Given this list of marker genes Lpar3, Cga, C030013C21Rik, Clip3, 9930111H07Rik, Wnk4, Bnip2, Ryr1, Psors1c2, Nhsl2, Limk1, Fndc5, Mcf2l, Adam15, 4930573O16Rik, Nog, Speer3, Tmem88, Tnnt1, Tmem150a, Fgd4, Gm19265, Myo1h, Tox4, Tlr4, 5430427M07Rik (RIKEN cDNA 5430427M07 gene), 4930505O20Rik, 1700124L16Rik, Dhcr7, Akr1cl, Sult1e1, Gng10, Fn3k, Csrnp3, Snorc, Ckmt2, Spata24, Ccdc28b, Tmed7, Vsir, Syne2, Or13c7d (olfactory receptor family 13 subfamily C member 7D), Foxc1 (forkhead box C1), 1700025A08Rik, 1700026J14Rik, Lrrc58, Phykpl, Pygo2, Abtb3, Rassf8, Dmrtb1, Add2, Meg3, Nrgn (NCBI Gene Id 97578), Lrrc4, Armc2, Galntl6, Zcchc12, Fgf15, Ncln, Sez6, Tead1, 1700061E18Rik, Zfp358, Prelid2, Anks6, Sapcd1, Socs4, Gpatch2, Trappc3, Nfatc2ip, Acer2, Zfp560, Myo5c, Pdxdc1 (pyridoxal-dependent decarboxylase domain containing 1), Pax3, Kctd4, Mef2c, Fxyd1 (NCBI Gene Id 80524), Lonrf3, ENSMUSG00000135196, Gtf2f1, Cthrc1, 3110080O07Rik, Ripor1, Ppp2r2a, Xrn1 (5'-3' exoribonuclease 1), Scpep1, Lyzl4, Galnt4, Myo5b, Sigirr, Dph1, Epdr1, Ccdc88c, Taf1b, Sh2d4b, Ccdc125, Rasip1, Vmn1r239-ps, Mag, Krt34, Prkcq, Rnf208, 4931414P19Rik, Mymk, Pgrmc1, Aspa, Bcl6, Tcap, Coro6, Fbxl22, Tex16, Ankrd48 (NCBI Gene Id 76389), Vtn, Adamts9, Sry, Ireb2, Akap5, Rhoh, Xpot, Arpc4, Pip5k1b, Acp5, Or51a10, Cyp2b9, Sdf4, Cyp11a1, Gpr155, Ano9, Elavl3, Kdm4b, Igsf5, A930041C12Rik (RIKEN cDNA A930041C12 gene), Col22a1, Nudt16l1, Trpv4, Dtd2, Clic4, Lypd3, Zfp235, Gcc2, Gstm7, Fahd2a, Lect2 (leukocyte cell-derived chemotaxin 2), Zfp536, Tmem63a, Rnf180, Airn, Wdr89, Abhd18, Rem1, 4930568A12Rik, Cacna2d2, Erp44, Cnn1, Fam240b, Dscam, 2310034O05Rik, Cyp1b1, Apoa4, Adgre4, Smim1, Prss36, Frat1, Clcnkb, Pdzk1ip1, Gngt2, Necab2, Cd248, Rnh1, Adora2b, Foxa2, Acsbg3, Slc25a23, Pla2g4a, Ttc9b, Actl6b, Hoxd3, Sobp, Ier3, Npas1, Dnaaf4, Cdhr5 (NCBI Gene Id 72040), Emid1, Dgke, Zfp773, B3galt5, Hspb2, Dhrs3, Cdh20, Cryaa, Zim1, Slc7a9, Slc44a4, Lpxn, Ctf1, Mbd4, Slc6a14, Nnat, Rhbdf1, Rflnb, Ykt6, Rab3a, Agtrap, Brsk2, Socs5, Sigmar1, Sema5a, Mybph, Ero1b, Evi5l, Mgst3, Dock5, Map7d2, 1600012H06Rik (NCBI Gene Id 67912), Try4, Map4, Csta2, 4932702P03Rik, Wdr86, Ppifos (peptidylprolyl isomerase F, opposite strand), Ggps1, Rnf220 (NCBI Gene Id 70613), Rasa2 (NCBI Gene Id 71394), Arhgef3 (Rho guanine nucleotide exchange factor 3), 9430024E24Rik, Mtnap1, Bhmt2, 1110065P20Rik, Spaca1, Bicd1, Ppfia3, Klc4, Ace2, Lat2 (linker for activation of T cells family, member 2), 4930524B15Rik, Rhox5, Gpr108 (G protein-coupled receptor 108), Rab11fip1, Gpc5, Cep295nl, Fkbpl, Arc, Cacna1s, Dmtn, Cd69, Nudt12, Fezf1, Agrn, Cbr2, Hesx1, Cib4, Cacng4, Lman1, Lxn, Lce1m, Mc4r, C2, Mpv17, Cyp4f13, Dnajb4, Gata1, Spmip6, Ildr2, Dysf, Actn3, 1700025G04Rik, 1700121L03Rik, 1700026N04Rik, Spryd7, Dchs1, Itga7, Tenm2, Npr2, Cryba2, Matcap1, Tob1, 3010001F23Rik, Cstpp1, Serpinb12, Gimap4, Zfp715, Cd247, Npl, 2810459M11Rik, Rnf6, Myo5a, Nlrp5 (NLR family, pyrin domain containing 5), Ucma, Fam162b, Plec, Sult1c1, Fos, Ttn, Ntm, Senp7, Ankrd24, Col11a2, Itgb6, Adam22, Jak3, B230112J18Rik, 4933411G06Rik, Metrn, Lenep, 2810032G03Rik, Uncx, Cma1, Chd6, Chodl, Tbk1, Per1, Vxn (NCBI Gene Id 98627), Plcl2 (NCBI Gene Id 29868), Rab31, Or2a7, P2rx1, Sema5b, Gm34939, Icam2, Lin7c, Ehmt1, Fyco1, Gosr1, Med1, Trappc12, Rnf111, Ube3b, 5330431K02Rik, Lnx1, Pds5a, Pbx2, Smad6, Apoa5, 2010109A12Rik, Car1, Gzma, Serping1, Mapk6, Aph1c, Smagp, Foxb2, Glipr2, Zeb2, Mok, Elane, Ero1a, Dnajb12, Lrp2, Vstm2b, Ahsg, Rnf125, 1700123O20Rik (RIKEN cDNA 1700123O20 gene), ENSMUSG00000140568, Nhsl1 (NCBI Gene Id 70502), 1700060C20Rik, Enpp1, Irx4 (NCBI Gene Id 50916), Krt12, Slc6a4, Tspan9, 4930573H18Rik, Defb1, Sh2d4a, Rufy3, Nadk2, Lysmd2, Lman2, Gstt1, Gapdh, Dcstamp, Or51e2, Dkk3, Ptgir, Wnt3, Nat3, Tmem86b, 4930543K20Rik, Csrp1, Kremen2, Kif5b, Il4, Apba2, ENSMUSG00000136010 (NCBI Gene Id 73064), Dpep3, Strn3, 4933401H06Rik, Npas3, Stac, Tbc1d5, Ptprd, Gldc, Spats2l, Lce3c, Klrc2, Chga, Dock4, 2010003K11Rik, Lhfpl4, Ccl27a, Siae, Apom, Calm4, Apcs, Gnpat, Ecel1, Pcnt, Rap1gapos, Fads3, Mzb1, Cntn1, Pcolce, Mospd3, Adamts8, Nat8l, Has1, Noc3l, Lamp5, Rgs7bp, Kctd10, Gm16527, ENSMUSG00000122613, Alpl (NCBI Gene Id 11647), Fam219a (family with sequence similarity 219, member A), Tek, Rab38, Itfg1, Col27a1, Mapre1 (NCBI Gene Id 99354), Kcnab3, Slc17a6, Zfp46, Cryga, 9330198I05Rik, Osbpl10, Ptcd1, Smim3, Ptch1, 4932412D23Rik, Sdc2, Zdhhc13, Prdm2, Sstr2, Fosl1, Pdgfc, 1500004A13Rik, Mplkip, Cat, Las1l, Bmp5, Cntnap4, Arpp21 (NCBI Gene Id 94243), Patj, Inhbb, Rab3c, Dnmbp, Cd47, Hgd, Mcoln2, Bend5, E130111B04Rik, Irak1, Ceacam11, 0610040J01Rik, 1110028F18Rik, Rsl24d1, Psg21 (NCBI Gene Id 72242), Acta2, Tmem161b, Kif16b, Klf9, Dspp, Nedd1, Helz, B230216N24Rik, Asic2, Krt16, Arrb1, Ubn1 (ubinuclein 1), Cfc1, Dbx1 (NCBI Gene Id 13172), Nme3, Plxna2, Rmdn3, Cldn3, Map3k4, Map3k1, Fem1b (NCBI Gene Id 14155), Cmya5 (cardiomyopathy associated 5), Ccdc93, Mapk10, Tspo, Prr29, Dkk1, Tapbp, Gjc2, Slco1c1, Ucp2, Eps8l3, Pacrg, Lhx1os, Tnfsf9, Kndc1, Cacng2, Bcas3, 9530050K03Rik, Rnd3, Eef1a2, Myo1b, Gipc2, Serinc3, 4930452G13Rik, Zfp958 (NCBI Gene Id 233987), Slc25a24, Ednra, Ngp, Sh3kbp1, Prss1, Resp18, Krit1, Sec16b, Col13a1, 9530086P17Rik, Lypd5, Zzef1, Dad1, Impa1, Cyp3a44, Lypd2, 4930540E01Rik, Leprot, Dhrs7c, ENSMUSG00000137098, Mxd3, Evpl, Kynu, U2surp, Clps, 5430431A17Rik, Tusc3, Xcl1, Hoxaas3 (Hoxa cluster antisense RNA 3), Mir142hg, Degs1, Ctsg, Lurap1l, Pik3r1, Tm4sf4, Myl7, Snx7, Amdhd1, Gm16499, Celsr1, Capn5, Fancd2os, Mrpl10 (NCBI Gene Id 97707), Atf3, Grhl1, Myl12a, Steap1, Creb3l4, 4930556J02Rik, Gpr65, Rac3, Asprv1, Cabcoco1, Myo3a, Gucd1, Tlr1, Gata3, Pgm5, Fcer2a, Pate4, 4930443O20Rik, Pctp, Ncmap, Or56a5, Slc25a53, Gabrg1, Hsd17b7, Uck2, Itga9, Vps37a, Glp2r, Atp8a1, Dock7, Cyp2j5, Myo1e, Neat1, Ppp2r2b, Slc25a30, Gatm, Zfp60, Elf5, Hsd11b2, Rgs8, Ift88, Ripor2, Dab2, Arsb, Atg2b, Atg16l2, Lrrc75aos1, Vamp2, Hipk2, Srpx, Traf5, Naaa, Spmip8, Nt5el, Twf1, Matn3, Acot10, Asl, Camsap3, Cltc, Pate13, Pou5f2, Flvcr2, Scube1, Gm17782, Rexo5, Ccdc198, Crlf2, Slx1b (NCBI Gene Id 75764), Pi4k2b (phosphatidylinositol 4-kinase type 2 beta), Kctd9, Ocstamp, Rptn, Ptpn5, 2600014E21Rik, Smim18, Ndp, Lrrn3, Taar1, Cecr2, Hivep3, Prlr, A930031H19Rik, Gpihbp1, Dmxl2, Mphosph10, Capg, Trib3, Mobp, Sez6l2, Map3k8, Maoa, Adgrl4, Cideb, Snap91, Caly, Shisal1, Vcam1, Abcg3 (NCBI Gene Id 27405), Pnkd, Mpv17l, Dcaf11, Kit (NCBI Gene Id 16590), Slc4a4, Cemip, Fbxo21, Spam1, Hoxc4, Stag3, Ddr1, Ascl1, Mb21d2, Aox1, Steap2 (six transmembrane epithelial antigen of prostate 2), Ptp4a1, Peds1, Atg101, 1700120K04Rik, Rps6ka4, Slc30a6, Slc22a16, Unkl, Cd209f, Gp9, Kirrel3, Snca, Slitrk1 (NCBI Gene Id 76965), Ap5s1, Zcchc4, Myoz1, Lrrc46, Gng3, Cyp2d26, Fmo5, Pgbd5, Calml4, Tenm4, Lca5, Rbm47, Hmbox1, Arhgef26, Slc35d3, Cadm3, Angptl6, Zfr2, Gnpnat1, Dynlt1b, St3gal2, Wnt6, Lysmd3, Acvr2b, Kcnn1, Gimap1, Ntrk2, Art3 (ADP-ribosyltransferase 3), Myl3, Wnt5b, Atp2b1, Fkbp1a, Kcnj11, Kcne1, Cbfa2t3, Entpd2, ENSMUSG00000131249, Pdcd4, Pnpo, Krt85, Cacna1g, Mirg, Pnoc, Utp23, Spag1, Pwp1, 4930567J20Rik, Rabif, Dmgdh, Elapor1, Smc2os, Ager, Aloxe3, Bicc1, Atp2a1, Lyve1, Tex101, Pigw, Misp, Pou3f2, Cav3, Tulp3 (TUB like protein 3), Bcl2, Art4, Wfikkn2, Vps33a, Oc90, Muc16, Cyp51, Flnc, Rab33a (RAB33A, member RAS oncogene family), Lcp2, 4930509H03Rik, Smarcd3, Ankrd22, Ect2l, 1700030K09Rik, 5730522E02Rik, Rnf151, Fxyd2, Mkrn2os, Hspbap1, Aldob, Ly6g6e, Bcl2l13, Wif1, Gsdma, 4930533K18Rik, Stk33, Cx3cl1, Tm4sf20, Zfp467, Egr2, Fetub, Mmp13, Ntn3, Rtn2, 1700042O05Rik, Itga5, Srprb, Zic4, Frmd5 (FERM domain containing 5), Rundc3a, Sall3, Cobl, Pcdhb16, Cldn11, Il1rl2, Gm20870, 2810408A11Rik, Pramex1 (PRAME like, X-linked 1), Klkb1, Nrbp2, Parp6, Slc46a3, Rbm18, Them5, Leap2, Wdr1, Ttc1, Smim5, Prrx2, Ankrd33b, Thy1, Trmo, Tex14, Ube2l6, Lipg, Nkd1, Mlkl, Akt3, Bpifa3, 4930513N20Rik, Stk38, 4833411C07Rik, Isyna1, Ttc9, Anpep, Grem1, Ifi44l, Magi1, Cpxm2, Cntfr, Sftpc, Clgn, Islr, Myo1c, Rasgrp1, Pcsk1n, Slc6a20b, Ms4a3, 4921504A21Rik, Anxa13, U90926, Paox, Fnbp1, Mcpt1, Map3k20, Chm, Zgrf1, Cldn34c1, Nup62, Prol1, 4933431C10Rik, Tspan33, Cmbl, Ncald, Slc39a4, Gprc5c, 2510009E07Rik, Cxcr5, Cuedc1, Dcakd, Isl2, Ttyh3, Glod4 (NCBI Gene Id 97734), Ces2c (NCBI Gene Id 234671), Rnf187, Zbtb20, Slc16a2, Rps6ka5, Myoz2, Pcnx4, 5330439K02Rik, Dbndd1, Fxyd7, Kbtbd11, Gla, Cldn13, Nkx1-2, Slc35f4, Dst, Spint1, Epx, Myt1l, Serpina3a, Cd93, Kcnj2, 2610306O10Rik (NCBI Gene Id 70460), Gpr160, Ippk, Itga2b, Dpf3, Hsf4, Nfil3, B3gnt2 (UDP-GlcNAc:betaGal beta-1,3-N-acetylglucosaminyltransferase 2), Gm2a (GM2 ganglioside activator protein), Cd164, Tubb4a, Ifitm3, Rrh, Abcc1, Camk2d (calcium/calmodulin-dependent protein kinase II, delta), Nol9, Ncan, Msto1, Appl1, Selenbp1, Rhag, Tecta, 4933421O10Rik, Ccdc134, Entpd1, Prp2, Cd55, Cacna1d, Tfr2, Tsr3, Map2k3os, Wnt10a, Slirp, Ppp1r1c, Gnao1, Cdh1, Brca2, Slc30a7, Tmem160, Cox7a2l, G0s2, 2310047K21Rik, Entpd8, Wnt5a, Apba3, 3110083C13Rik, Tfdp2, Agbl3, Cel, Ddx25, Tnc, Tax1bp3, Dhodh, Cyp4b1, Vrk3, Gabra2, Tmem163, Car5a, 2900060N12Rik, Gprasp1, Or14r1-ps1, Rasgrp2, Fbln7, Zfp661, Nr3c1, 2700069I18Rik, Ywhag, Gnaz, Aff3, Sst, Slpi, Acan, Kif3b, Cnot10, Sox11, Cebpb, Emc6, Xntrpc, Lypd8, Il17ra, Bcl11b, Ldb2, Snord7, Cpb2, Prdm16, Stk32b, S100a14, Prl2c2, Vsx1, Zfp719, Pou2f1, Egfl6, Sec62, Klf12, Cmtm5, Hpx, Pag1, Bcar3, Serpinh1, Bdh1, Rflna, Prkci (protein kinase C, iota), Supt4a, Akr1c12, Pdia2, ENSMUSG00000130051, Pecam1, Hsd17b3, Ankrd2, Svip, Mir205hg, Asb2, Pde7a, Spmip4, Tmem106b, Dock6, 5730435O14Rik, 9130002K18Rik, Lmod1, Ctse, Atxn10, Med15, here is a description of the gene set: Mouse Gene Set: BRUINS_UVC_RESPONSE_VIA_TP53_GROUP_A species: Mus musculus Category A genes: p53-dependent genes whose expression in the absence of S389 phosphorylation is similar to loss of TP53 in MEF (embryonic fibroblast) cells in response to UV-C irradiation. from publication Bruins W, Bruning O, Jonker MJ, Zwart E, van der Hoeven TV, Pennings JL, Rauwerda H, de Vries A, Breit TM (PMID 18195040) Phosphorylation is important in p53-mediated DNA damage responses. After UV irradiation, p53 is phosphorylated specifically at murine residue Ser389. Phosphorylation mutant p53.S389A cells and mice show reduced apoptosis and compromised tumor suppression after UV irradiation. We investigated the underlying cellular processes by time-series analysis of UV-induced gene expression responses in wild-type, p53.S389A, and p53(-/-) mouse embryonic fibroblasts. The absence of p53.S389 phosphorylation already causes small endogenous gene expression changes for 2,253, mostly p53-dependent, genes. These genes showed basal gene expression levels intermediate to the wild type and p53(-/-), possibly to readjust the p53 network. Overall, the p53.S389A mutation lifts p53-dependent gene repression to a level similar to that of p53(-/-) but has lesser effect on p53-dependently induced genes. In the wild type, the response of genes to UV irradiation was strictly biphasic. The early stress response, from 0 to 3 h, results in the activation of processes to prevent the accumulation of DNA damage in cells, whereas the late response, from 12 to 24 h, relates more to reentering the cell cycle. Although the p53.S389A UV gene response was only subtly changed, many cellular processes were significantly affected. The early response was affected the most, and many cellular processes were phase-specifically lost, gained, or altered, e.g., induction of apoptosis, cell division, and DNA repair, respectively. Altogether, p53.S389 phosphorylation seems essential for many p53 target genes and p53-dependent processes.